The following is a description of a gene set: species: Homo sapiens The process of creating protein oligomers, compounds composed of a small number, usually between three and ten, of component monomers that are not all identical. Oligomers may be formed by the polymerization of a number of monomers or the depolymerization of a large protein polymer. Human Gene Set: GOBP_PROTEIN_HETEROOLIGOMERIZATION, and this is the list of marker genes: FARSA, ROM1, GRIN2B, CD2AP, PRPH2, TMEM120A, COL1A2, PKD2, CPSF6, ZNF746, KCNC2, CALHM3, SYT1, KRT10, CPSF7, ZNF777, ARHGAP27, NUDT21, CALHM1, KRT1, RRM1, CBR4, FARSB, MAT2A, HSD17B8, RRM2, PKD1, SGTB, GRIN1, TMEM120B, GRIA3